Given this list of marker genes KPNA2, SEMA3D, FAM8A1, SLC12A6, ABI3BP, BMPR2, PPP1R15B, SGMS1, SCAF8, SLC36A4, HCFC2, ZIC3, SMG7, RERG, ELAVL2, RHOQ, WDR26, FBXO38, HAT1, KIF1B, UBFD1, POU5F1, ZNF559-ZNF177, MACIR, LSM12, SUZ12, MYLIP, CYP20A1, CTLA4 (NCBI Gene Id 3411), METTL8, GGT7, IL5RA (NCBI Gene Id 3568), LRRK2, HNRNPD, PRLR, TMEM215, NUP153, TRDN, CEP44, ANKRD17, SOX30, CSDE1, PCDH7 (protocadherin 7), C1orf21, SOAT1, INTS6, WDR7, IL5, LYSMD3, LRIF1, DIP2B, MBOAT2, KLHL2, PNISR, GCA, NRG4, MAK16, ZNF438, FBXO45, COCH, MFSD6, ZFP28, YIPF5 (NCBI Gene Id 81555), MARCHF1, CNOT6L, GABRB2, BACE2, PCDHB4, DCUN1D1, VAMP7, LRRTM3, RNF157, PARD6B, PCDHA12, AADAC, RELT, ICE1, SLC25A17, LGR5, KRTAP9-9, SPTSSA, PPM1A, ELK4, BLTP3B, GARRE1, CCDC182, ZNF555, TSPAN19, TWSG1, CAMK2N1, ZNF652, PRRT2, INSC, IGF1, LRP5L, SOS1, PF4V1, POU2F1, GPC5, PFDN4, GOLGA7, ZNF730, MRE11, LRRTM2, ERBB4, DNAJC3, SNX9, NSUN7, PRTG, DOCK7, TCF3, RRP15, PTGR3, GDF6, RAB6A (RAB6A, member RAS oncogene family), SLC25A37, COX20, TRA2A, PTAR1, GPC2, RB1, ATRNL1, PAPSS2, MBTD1, SBDS, RNF180, RBBP5, MON2, RHEB (Ras homolog, mTORC1 binding), BTBD7, TXNDC9, PCDH11X, HIPK3, HIVEP2, TMEM165, C1orf43, ZNF254, ANTXR1, TRPA1, AGFG1, PRKAR1A, EEA1, PCDHAC1, NME5, ATAD2 (NCBI Gene Id 84325), INSM1, C2orf80, RBP3, VPS26B, PCDHB9, SASH1, PLAGL1, PLEKHA5, GTF2F2, ARFGAP3, DRAP1, SLC11A1, AMIGO2, PPP1R3B, MICU3, HMGB1, GXYLT1, PABPC3, LPAR4, SLC9A6, SMARCE1, CELF2, ZNF780A, TRPC5, FGF7, CDYL, ANAPC7, MINDY2, MGAT4A, FAM162A, PYHIN1, VWA8, PAK5, SETBP1, PDE7A, ZNF177, SNX7, CBL, SC5D, ZDHHC23, C1orf198, PGGT1B, XRN1 (NCBI Gene Id 54464), FGB, CYB5R4, SDE2, PROK2, GGNBP2, ZEB2, ATOH7, STAT1, IDH3A, PM20D2, FSBP, MYO5A, GPR180, PALS2, TMEM167A, RAB21, STAM, SCP2, GLCE, ME1 (malic enzyme 1), PRMT9, RAB3C, BBOF1, CYFIP2, SERTAD2, ARL5B, PCDHA5, GCSH, B3GALNT1, SRI, DUT, CKAP4, PTMA, PCDHA8, PPM1E, SLC35F5, CXADR, SMC5, DRP2, ASPN, FAR2, HEG1, TAB3, AMOTL1, MAGEB4, DCBLD1, KCNB2, ZBTB7A, RPRD1B, PMS1, VAPB, CRY1 (cryptochrome circadian regulator 1), NFXL1, HMGB3, SREK1, PCDHAC2, KLC4, CEP120, LARP7, RTL3, UBE2V2, HAPLN1, TMED5, CMKLR2 (chemerin chemokine-like receptor 2), SEC63, PAXBP1, CD99, DLL1, ARL13B, SLC7A14, PAX5, MCUR1, FAM120A, NIPAL1, PRKD3, ZNF354C, LYRM1, UBE2D1, HDAC9, PTEN (phosphatase and tensin homolog), PCDH1, SLC22A2, HMCES, MYEF2, FZD3, PIEZO2, DGKH, CLCN2, SPAG9, FNIP1, IKZF2, CDH9, UBLCP1, MACO1, UBE2K, CCNC (cyclin C), AMER1, ATRX (ATRX chromatin remodeler), RAB2B, AJUBA, ZBTB20, PCYOX1, SLC6A14, MBLAC2, NUDT21, ERI1, GUCY1B1, AASS, TPSG1, R3HDM1, PPIG, CADM1, TTPAL, DKK1 (NCBI Gene Id 22943), EPB41L5, ABHD5 (NCBI Gene Id 51099), PDIK1L, NCBP3, CAVIN2 (caveolae associated protein 2), STX17, CYTIP, NAA30, ZNF407, SLK (STE20 like kinase), PCDHB16 (NCBI Gene Id 57717), CALN1, KDM5D, RSPRY1, PGAM5 (NCBI Gene Id 192111), DR1, POLR3F, ZC3H7B (zinc finger CCCH-type containing 7B), SESN3, RAC1, G3BP1, PLCG2, KRAS, CFAP52, SHMT1, NUP54, PPP1R17, SLC25A31, IL6R, PLOD2, GPR85, ZKSCAN4, PGM3, YWHAQ, XPNPEP3, SH3GLB1, RWDD4, WWC2, MCTS1, FMR1, NRXN1, PIP5K1A, IDI1, FAM3C (NCBI Gene Id 10447), RPS6KB1, PI15 (peptidase inhibitor 15), RNF38, EDEM3 (NCBI Gene Id 87240), TRNP1 (NCBI Gene Id 388610), TMCC3, BLOC1S2, TRPC6, WDR47, GPR65, NADK2, SCAI (NCBI Gene Id 286205), SLC30A4, BRAF, PALS1, POLR2D, PHC3, SOX4, DNPH1, SPAST, LRRC8D, CBLL1, RBP1, MED12L, PCDHA11, LDAF1, TM9SF3, SMCO3 (single-pass membrane protein with coiled-coil domains 3), VASH2, SLC17A6, TMED10, PCDHA4, ATP2B1, HAUS6, SP4, SNX16, GPATCH2L, GRIA1, SLC30A7, ZCCHC10, ISL1, MASP1, MZT1, MAPK4, PPP3CA, DYNC1I1, LRRTM1, SLC25A24, RAD54B, FDX1, SFT2D3, BLVRA, LMAN2, FOSL2 (NCBI Gene Id 79579), GPR15, SEH1L, TET1 (tet methylcytosine dioxygenase 1), KLRC2, DISC1, FBLN7, CPNE3, DIAPH2, GATAD1, PLPPR4, CDK6, FGFR2, YTHDC1, MATN4, NAP1L5, DCUN1D4, COL4A2, KIF3A, PURB, TMEM100, TWF1, FAM237A, PPP4R3B, NLGN3, FBXO30, TVP23C, DNAJC22, AUTS2, NAMPT, KANSL3, LIN9, RUNX1T1, COL5A2, FOXO1, TNRC6B, TRERF1, CNIH1, ZC3H6, NPEPPS, SLC39A3, INTS7 (integrator complex subunit 7), LDLR, ECT2L, TFEC, RAI14, NECAB1, RALYL, GPR88, PROSER1, TEX2, DSCC1, BRD3, ACOX1, SNX10, SLC5A8, PLEKHA8, HSPA4L, MTF2, TMEM33, CRYBG1, PNPLA8, TCF21, CLIP4, RBM4B, TBL1XR1, PCDHA2, ATAD1, MB21D2, APELA, ZBTB2, CAST, PCDHA13, ATXN3, PLAGL2, ARGLU1, MAP3K1, ZBTB21, CREB3L2, PHACTR2, REEP3, ZDHHC15, COBL, IPO7, COL25A1, ABHD17C, GYG1, NUP98 (nucleoporin 98 and 96 precursor), PTGER3, CLEC4D, CREBZF, NUP50, DDX43, PRC1, PCDH19, TMEM178B, TMEM132E, CCDC138, DSG1, UQCC6 (NCBI Gene Id 732143), CEP97, PCMTD1, TBC1D15, FAM107B, SCGB2B2, MSI2, TOB2, ANAPC5, GPR183, MTERF3, CHMP1B, ANO5, UHMK1, DEPDC1 (NCBI Gene Id 55635), WDFY1 (WD repeat and FYVE domain containing 1), CDH1, AKNAD1, MDFIC, CCNT2, MAPKAP1, STC1, LMLN (NCBI Gene Id 89782), AGPS, ARPC1B, TRPS1, CENPK, FH, VANGL2, RWDD2A, PEG3, LMAN2L (NCBI Gene Id 84746), DACH1, ZNF34, CLOCK, DCK, RREB1, RNF217, DENND1B (NCBI Gene Id 54530), ASPA, MID2, CAMKK2, ZXDB, SRPK3, PYROXD1, PCDHA1, SSR3, ADRA1A, TTC28, SOX6, PGBD2, ZBTB1, ENOX1, RALGPS2, B3GALT2, BCOR, VKORC1L1, FOXN2, LONRF1, AMN1, MSL2, TPRG1, DCDC2 (NCBI Gene Id 606719), DLG1, RAB9B, B3GNT2, ARID5B, TET2, FAM47C, NUTF2, CMTM8, NUMA1, PPP1CB, SMAD5, KDM7A, ZMYND11, ADAM12, DHX40, ANGPT1, MED13, DNAJC5G, PDCD4, SLCO3A1, LMO7, CUL2, SUV39H2, STK26, MAP2K1, PPP3CB, FGF5, DDX53, NAA50, DCLK1, CCL8, RO60, STXBP5, SLC4A7, ZBTB44, MAP3K2, IFNGR2, COL6A5, LRP2BP, GABRA1, EPDR1, GALNT2, ZNF491, INSIG1, RNF144B, PUS10, CARNMT1, ADAMTSL3, ZMAT1, LIN7C, RBM27, SLC2A13, PCDH11Y, EIF1AX, ATXN7, WNK3, BMP3, ETS1, PIGM, CTH, LITAF, SMIM14, EPM2AIP1 (NCBI Gene Id 9852), TSLP, TCEA1, EIF4E3, RC3H2, LRRC58, PLEKHA3, CNKSR2, KLHL24, IL23R, FAM13C, ITPRID2, TMEM255A (NCBI Gene Id 55026), DDX46, GEM, SLC9A2, FUT9, ODF2L (NCBI Gene Id 57489), BET1, ADSS2, SOS2, HDAC2, SLC7A1, TMEM131, WDR41 (WD repeat domain 41), WDR33, ELMOD2, CETN3, DUSP16, RFX1, CDH26, MAPK6, POU5F1B, TMEM170B, ELAVL4, EDDM3A, RTKN2, TPBG, ATP1B4, SEMA5A, SPRYD7, ARL5A, CCDC102B, SMAD3, TRIM38, SPRED1, RAB30, BNIP3L, PHLDA1, SEC23IP (NCBI Gene Id 11196), PRKAA2, CSNK1A1, NHS, MGA, USP44, GFM1, MOB1B (MOB kinase activator 1B), ZNF618 (NCBI Gene Id 4740), CLMN, OTOGL, TMEM184A, GNB4, CCDC93, HYCC1, SLC4A4, ZFX, MACROH2A2, PCDHA6, ALDOB, ICMT, MARS2, CDK14, G2E3, RABGEF1 (NCBI Gene Id 27342), RCBTB1, RRM2, MYSM1, TRAPPC2, RAP2B (RAP2B, member of RAS oncogene family), MYL1, REPS2, DCUN1D5, FOXN3, INO80, EVC, GPC6, CD55, GLYATL2, USF3, WASL, SLAIN2, PCDHA7, GSK3A, RAD23B, KHDRBS1, MKLN1, BRWD3 (NCBI Gene Id 254065), VSTM2A, UCHL5, SKP2, PCDHA3, PTGR2, HIF1A, ABCG2, TLCD4, NABP1, SEC24A, CLCN3, FNBP1L, DNAJB4, FAM210B, ERO1B, PEX2, CTDSPL, FBRSL1, HOXB2, ELAVL1, SRRM2, ZMPSTE24, PCDHA10, TMEM241, TRIM5, ARID4B, FBXL3, COLGALT2, TBC1D23 (TBC1 domain family member 23), TRIM33, KRIT1, ITGB8, GABPA, OPRK1 (opioid receptor kappa 1), BACH2, CCDC186, RNF44, SHOX, TNFRSF21, IGF2R, NCAPH2, ZBTB4, CISD1, KSR1, LRP6, NUFIP2, RBM24, TMEM168, MLLT3, ABI2, QKI, CNRIP1, CAPN12, TCF12, KLHL28, ZNF280D, KIF5B, FUCA2, PIK3CG, PLXDC2, MRPS14, PCDHA9, PDE1C, MAN1A1, XIAP, PLPPR5, HIVEP3, PANK3, HS3ST3A1, LRAT, RANBP3L, SCN1A, ZIC5, TRAPPC13 (NCBI Gene Id 80006), KLHL8, RPGRIP1L (NCBI Gene Id 23322), MDM2, NUDT13, BRINP2, MBL2, FCHSD2, RBM18, HNRNPF, CDCA4, MTFR1L, TTC33, BTG3, ZFP91, GHR, CDKN2AIP, GBP1, PIGA, CILK1, ZNF711, USP42, KLRC1, MYLK3, OSBPL3, RASAL2, here is a description of the gene set: Genes predicted to be targets of miRBase v22 microRNA hsa-miR-3658 in miRDB v6.0 with MirTarget v4 prediction scores > 80 (high confidence targets). Human Gene Set: MIR3658 species: Homo sapiens from publication Chen Y, Wang X (PMID 31504780)